The following is a description of a gene set: studied in species Mus musculus Any process that modulates the frequency, rate or extent of G protein-coupled receptor internalization. Mouse Gene Set: GOBP_REGULATION_OF_G_PROTEIN_COUPLED_RECEPTOR_INTERNALIZATION, and this is the list of marker genes: Necab2, App, Apela, Apln, Ubqln2, Aplnr